Given this list of marker genes LIM2-AS1, ESPN, MED21, PPATP1, RNU6-1340P, NPAT, COPS5P1, CTNNA2, LINC00581, NAPSA, FMN2, MTND1P14, LINC01485, RNU6-847P, RFC1, SDC4, MTFMT, PMM1, NOL6, MIR3908, ENSG00000244137 (NCBI Gene Id 107985359), HAPLN2, GAS8, CFAP299, MLST8 (MTOR associated protein, LST8 homolog), BORCS6, ZNF675, LINC01235, ARMH3, ADA, LYN, MB, RLIG1P2, COPS3, PPP1R42, RN7SKP270, RNU4-62P, DHTKD1, SDAD1P3, ENSG00000202059, RNU6-916P, GLG1, RORA, SYCE2, MIR3162, RNU6-386P, ACACA, ITGAL-AS1, QSER1, IGSF21, CROCCP3, TRPV1, GDI2, CCDC65, RNU6ATAC36P, ENSG00000265246, ARPC1A, CMKLR2-AS, RB1CC1, CLDN23, MAP4K5, OR1X5P, DUS2, RNU6-1003P, C2CD5-AS1, VOPP1, MIX23, SLC6A1 (NCBI Gene Id 6529), C6orf141, RPL32P27, TRIM15, GLRX5P2, FRMD7, SNAP25, TPRXL, SPATS2L, GTF2I, ANGPTL6, CENPV, DNAI4, SLC22A11, LINC01641, C1orf87, AGMAT, SPMIP10, PTPN2, LINC02390, CCNB3, RNU6-166P, HNRNPMP2, TTC1, SOX9-AS1, LUZP1, TMEM98, MIR3529, TCEAL8P1, ASS1P5, AP1S3 (adaptor related protein complex 1 subunit sigma 3), LYPLA2P1, PTK2B, SSX7, STX4, FABP5P3, PLA2G4C, GXYLT2, BBLNP1, KRT18P45, NPLOC4, MORF4L1P5, CDCA7P1, SNHG30, DAZAP2, TNFRSF12A, ANGEL1, ACER3, RNA5SP474, NLE1, ILDR1, CYP1B1-AS1, RN7SL93P, PFAS, PLA2G15, WNT8A, EXOSC2 (exosome component 2), SCN3B, SLFN12, JAZF1-AS1, SLC25A16, KAT8, RRN3P1, ALDOA, CWC25, GIT2, TNFRSF10B, FAM177A1P1, UTP4, FCHO2, CEACAM21 (CEA cell adhesion molecule 21), CD160, RND1, SPEG, SH2B3, GALNTL5, IL16, DAGLB, MTO1, TGFB1, NUCB1-AS1 (NCBI Gene Id 100874085), CDK4, COQ10A, HEBP2, LIPA, VPS39, TPM4P1, FES, AURKB, ENSG00000187951, RPL36, YAP1P1, here is a description of the gene set: Human Gene Set: PRDM12_TARGET_GENES Genes containing one or more binding sites for (PRDM12) in their promoter regions (TSS -1000,+100 bp) as identified by GTRD version 20.06 ChIP-seq harmonization. from publication Yevshin I, Sharipov R, Kolmykov S, Kondrakhin Y, Kolpakov F (PMID 30445619) species: Homo sapiens